Given this list of marker genes MT3, MT1G, PARP1, LTA4H, KCNK3, P2RX5, SLC30A10, MT1DP, MT1H, VCAM1, SOD2, GLRA1, KHK, DDX19A, ASS1, MT1A, MT1F (metallothionein 1F), MT2A, OTC, ZACN, ALAD, MT1E, CREB1, GLRA2, ZNF658, S100A8, SLC30A2, ABCC8, SLC30A1, GABRB3, HAAO, BGLAP, MT1M, CRIP1, TSPO (NCBI Gene Id 706), CPS1, ATP13A2, SLC30A3, MT4, P2RX7, MT1X, MTF1, MT1B, AANAT, D2HGDH, PAM, HVCN1 (NCBI Gene Id 84329), SLC30A8, MT1HL1, PLN, SLC30A4, P2RX4, SLC30A5, here is a description of the gene set: Any process that results in a change in state or activity of a cell or an organism (in terms of movement, secretion, enzyme production, gene expression, etc.) as a result of a zinc ion stimulus. Human Gene Set: GOBP_RESPONSE_TO_ZINC_ION studied in species Homo sapiens